Given this list of marker genes CX3CR1 (C-X3-C motif chemokine receptor 1), RGR, UTP14C, TRAK2, POU4F3, P3H1, NBR1 (NCBI Gene Id 9740), GRAMD1B, TRPC2, LEPROTL1, DCHS1, CBLN1, EPM2A, PRKCSH, TNFSF15, IMPDH1, SERPINI1, ALDOC, SLC34A1, EXTL3, ATP6V1A, BRIP1, F5, MKRN1 (makorin ring finger protein 1), TKFC, LYPD1, OR2B6, LTC4S, VIPR2, SSX5, CBX5, MLXIPL, PTPRJ, RNASE2, HES2, C11orf71, CAMKV, SKP1, GPNMB, TRPM8, SCN10A, PRDX1, GDAP2, WDHD1 (NCBI Gene Id 11169), ANP32CP, SPATA6L, CD2BP2, DGKG, SH2B1, VAMP2, GLT8D1, ZNF280D, KIF17, FKBP6, CYLC2, IDH3A, TMT1A, ATP5PD, TMEM94, CCDC121, BCAS3, GJA4, STMN2, RMND5B, MAGEA5P, AEN, CDH8, ME3, MEIS2, MED6, TM7SF3 (transmembrane 7 superfamily member 3), PRPH2, SPN, ADGRG3, PID1, GTF3C2, BCAN, CDKN2C, TLX2, FOCAD (NCBI Gene Id 54914), GNB5, HMGCL, PRL, GPX4, SLC30A6, CPA4, CYP1A1, HLA-F-AS1, HS6ST1, PDIA5, PIM2, TUBGCP5, PRR4, ADRA1B, PSMC3, GOLM1, SOX21, RTF1, TK1, DOP1A, TMED1, ABCB7, RAD51B, MFF, HHLA2, HHLA1, ABHD8, POGLUT2, ZPR1P1, VWA7, ARHGAP11A, TCF4, SAFB, CFB, FAM117A, DENND2D, H2BC4, C9orf78, CELA3B, MSX1, LIN37, KLRC3, GSTZ1, KIT, RNF146, TCF20, SLC17A1, NRL, TSN, ZNF510, BTBD7, GLOD4, GPI, SERHL2, TMEM187, SRPX, CA2 (carbonic anhydrase 2), LMCD1, HSD17B6, MYOZ2, VPREB1, MLLT3, NUDT6, GPN2, VWF, LAMTOR5, LINC00339, PHF3, ZNF84, MTPAP, S1PR1, PDE6D, ASPA, CLPX, GALK2, LAPTM4A, MRPS30, DLC1, HTR2A, MGST2, ASRGL1, RPL36AL, LHB, GLRB, MYBPC1, LIN28A, SAP30, ALDH5A1, OSBPL11, MEFV, CLEC4M, RRAGD, DLGAP2, RBP3, GRIN1, FCER2, CEACAM3, USP21, NR1D2, YY1AP1, ZNF330, SS18L1, GUCY2F, SLC48A1, CFAP70, GTPBP10, EIF2S3, CCNK, CHRNG, LEMD3, TLR4, PCMTD2, ERMAP, MYNN, TUBA3D, SLIT3, BICDL1, CCT6A, here is a description of the gene set: Human Gene Set: GSE20152_HTNFA_OVERXPRESS_ANKLE_VS_CTRL_SPHK1_KO_ANKLE_DN species: Homo sapiens Genes down-regulated in ankle joints from SPHK1 knockout: TNF over-expression versus control. from publication Baker DA, Barth J, Chang R, Obeid LM, Gilkeson GS (PMID 20644167) The study analyzes analyzes gene expression changes in the ankle joint in mouse TNFa overexpression models with or without sphingosine kinase 1 activity. SphK1 is a sphingolipid enzyme that converts sphingosine to bioactive sphingosine-1-phosphate (S1P). Recent data suggest a potential relationship between SphK1 and TNFα and have implicated SphK1/S1P in the development and progression of inflammation. Here we further study the relationship of TNFα and SphK1 using an in vivo model. Transgenic hTNFα mice, which develop a spontaneous arthritis (limited to paws) at 20 weeks, were crossed with SphK1 activity null mice (SphK1-/-) to study the development of inflammatory arthritis in the functional absence of SphK1. Results show that hTNF/SphK1-/- have significantly less severity and progression of arthritis and bone erosions as measured through micro-CT images. Additionally, less COX-2 protein, mTNFα transcript levels and fewer Th 17 cells were detected in the joints of hTNF/SphK1-/- compared to hTNF/SphK1+/+ mice. Microarray analysis of the ankle joint showed that hTNF/SphK1-/- mice have increased transcript levels of IL-6 and SOCS3 compared to hTNF/SphK1+/+ mice. Finally, fewer mature osteoclasts were detected in the ankle joints of hTNF/SphK1-/- mice compared to hTNF/SphK1+/+ mice. These data show that SphK1 plays a role in hTNFα induced inflammatory arthritis, potentially through a novel pathway involving IL-6 and SOCS3.